The following is a description of a gene set: A gasdermin-dependent inflammatory response that is associated with the generation of pyrogenic mediators such as IL-1beta and IL-18. Gasdermins are activated by caspase-1 or caspase-4/11, or by certain granzymes. In some, but not all cells, it can lead to pyroptotic programmed cell death. studied in species Homo sapiens Human Gene Set: GOBP_PYROPTOTIC_INFLAMMATORY_RESPONSE, and this is the list of marker genes: IFI27, NLRP6, ZDHHC9, GSDMB (gasdermin B), GSDME, AIM2, DPP9, APIP, CASP6, ELANE, ZBP1, MAP3K20, NLRP1, PYCARD, TREM2, ZDHHC5, NLRP9, CASP3, GSDMA, NINJ1, TRIM21, MEFV, GZMB (NCBI Gene Id 3002), GBP3, MIR223, DHX9, CARD8, GBP2, GBP1, GSDMD, NLRC4, NAIP, CASP4, GBP5, CASP1, GZMA, NLRP3, ZEB2, CASP8, GSDMC (NCBI Gene Id 56169)